Given this list of marker genes IRF7, L1TD1, ACAP1, FADS1, PRSS3, ZNF112, FCER1G, SRPX (NCBI Gene Id 8406), RNASE4, MYO9B, ATP6V0C, CPT1A, MYO5C, THEMIS2, RBMS3, GABRR2, TYROBP, PSD4, ANKRD55 (NCBI Gene Id 79722), CLPTM1, RNH1, H1-10, NPTX1, SIX6, AKAP12, NUMA1, PLXNC1, CD38, SH3GLB2, IGLC2, PNP, C1orf159, AEBP1, PRKCSH, TGFBR3, RFXANK, NMB, IP6K1, KLF10 (KLF transcription factor 10), CDK10, OGT, IGLV3-25, GATA3, RHOT2, IGF1R, PAK1, SPAG4, AKR1D1, HPCAL1, PHEX, MAN1B1, LDOC1, GRK2, CD9 (CD9 molecule), PLD1, CD5, OR2B2, CRY1, SERPINF1 (serpin family F member 1), OGFR, ITGA4, CHST12, IL6R, PATZ1, TKT, ATP5F1D, CTXND1, COPE, TM7SF2, MED15, ARHGDIA, FGFR1, ABR, IGHV3-33, POLM, DPYSL2, CCL3, HOMER2, GLUL, RYR3, BMERB1, PGLS, MAST4, SFTPB, ZNF702P, MX1, ARMCX1, ZSCAN18, LINC00342, ST6GALNAC4, ENOSF1, OR10H3, DIAPH1, CTSF, C8orf17, ARHGEF1, ROGDI, VAMP2, DNM2, PRF1, PTPN18, ERBB4, LAMA5 (laminin subunit alpha 5), MAN2B1, PBXIP1, HLA-G, CABIN1, DNAJB2, PIM2, SLC16A3, FZR1, CD6, NRG1, ADAMTS3, TIMP1, SOWAHC, PARVB, GRINA, XAB2, CBX4, NEDD4, MAD1L1, DUSP6, TBC1D1, CDK11B, CDC37, TSPO, LILRB2, SNRNP70, OR7E24, ACVR2A, EIF4EBP1, ZDHHC11 (zinc finger DHHC-type containing 11), FAM174B, RRBP1, PON2, MEF2D, CR2, DAPK3, ARID5A, PXN, IGHD, ZBTB48, HNRNPUL1, ADAMTS6, NCAN, IGSF3, SLC25A1, UQCRC1, CEACAM1, GM2A (ganglioside GM2 activator), MYB, NUCB1, TMEM259, EHBP1L1, CAPG, SERPINE2, YES1, CASP10 (caspase 10), TPST2, MATCAP2, ERCC1 (NCBI Gene Id 2067), TMSB15A, C4A, CNKSR1, TMEM45A, GYPC, P2RX1, RHOBTB3, IGKV3-20, KLK2, GRN, LDB1, RFNG, CLCN5, PLPP3, PTPRCAP, TKFC, TIMP3, ANG, ZNRD2, MZB1, BPIFA1 (NCBI Gene Id 51297), RNF41, TLE1, HS3ST1, DMD, LPL, SH3TC1, TRIM2, FZD1, GALNT2, COMMD4, RAPGEF1, CNR1, IL16, SEPTIN9, PPP1R15A, GAA, ATF5, WNT5A, NCKAP1, NEU1, BTG2, ARHGAP44, SEPTIN10, SPART (spartin), CEBPD, LTK, PRRC2A, MRPL4, ANGPT2, LAG3, FOXO3, JUND, EFHC2, STXBP2, ARL4D, CCR2, IGLL3P, LDLRAD4, RIN3, SERTAD3, PEA15, PSD3, NAGLU, MAN2C1, NCF2, BLK, ATL2, ATP2A3, INO80B, FRMD4B, NCR2, RCAN3, SF3A2, THNSL1, IL17RB, MEST, PDE3B, CYP2A6, ATP11A, ZYX, FA2H, MAPKAPK2, S100A11P1, GGA3, CRIP1, DCAF15, PNMA2, RHOB, PIPOX, DUSP5 (dual specificity phosphatase 5), IGHV1-69, S100A11, SPRED2, CDKN1A, CLEC2B, MGAT4B, ZAP70, GATM, RXRA, MSRB2, ANXA1, OGDH (NCBI Gene Id 4967), LILRB4, MYO15B, PPP2R2B, CXCR3, HGS (hepatocyte growth factor-regulated tyrosine kinase substrate), ZSCAN32, B3GALNT1, KRTAP4-7 (NCBI Gene Id 85287), TNFRSF1B, IFI44, S100A13, PRLR, H2AC6, H2AC18, ITGAL, SGSM2, IGHV3-21, PRKCA, EGLN3, here is a description of the gene set: Human Gene Set: HUTTMANN_B_CLL_POOR_SURVIVAL_UP from publication Hüttmann A, Klein-Hitpass L, Thomale J, Deenen R, Carpinteiro A, Nückel H, Ebeling P, Führer A, Edelmann J, Sellmann L, Dührsen U, Dürig J (PMID 16932341) B-cell chronic lymphocytic leukaemia (B-CLL) is a heterogenous disease with a highly variable clinical course and analysis of zeta-associated protein 70 (ZAP-70) and CD38 expression on B-CLL cells allowed for identification of patients with good (ZAP-70-CD38-) and poor (ZAP-70+CD38+) prognosis. DNA microarray technology was employed to compare eight ZAP-70+CD38+ with eight ZAP-70-CD38- B-CLL cases. The expression of genes differed significantly between the two subgroups, including genes involved in B-cell receptor signaling, angiogenesis and lymphomagenesis. Three of these genes, that is, immune receptor translocation-associated protein 4 (IRTA4)/Fc receptor homologue 2 (FcRH2), angiopoietin 2 (ANGPT2) and Pim2 were selected for further validating studies in a cohort of 94 B-CLL patients. IRTA4/FcRH2 expression as detected by flow cytometry was significantly lower in the poor prognosis subgroup as compared to ZAP-70-CD38- B-CLL cells. In healthy individuals, IRTA4/FcRH2 protein expression was associated with a CD19+CD27+ memory cell phenotype. ANGPT2 plasma concentrations were twofold higher in the poor prognosis subgroup (P<0.05). Pim2 was significantly overexpressed in poor prognosis cases and Binet stage C. Disease progression may be related to proangiogenic processes and strong Pim2 expression. Up-regulated genes in B-CLL (B-cell chronic leukemia) patients expressing high levels of ZAP70 and CD38, which are associated with poor survival. studied in species Homo sapiens